The following is a description of a gene set: species: Mus musculus Any process that stops, prevents, or reduces the frequency, rate or extent of the chemical reactions and pathways involving lipoproteins, any conjugated, water-soluble protein in which the nonprotein group consists of a lipid or lipids. Mouse Gene Set: GOBP_NEGATIVE_REGULATION_OF_LIPOPROTEIN_METABOLIC_PROCESS, and this is the list of marker genes: Dbi, Hhatl, Itgb3, Itgav (NCBI Gene Id 76358), Apod